The following is a description of a gene set: species: Homo sapiens Catalysis of the transfer of a galactose residue from a donor molecule to an oligosaccharide, forming a beta-1,3-linkage. Human Gene Set: GOMF_BETA_1_3_GALACTOSYLTRANSFERASE_ACTIVITY, and this is the list of marker genes: B3GNT5, C1GALT1C1L, B3GALT5 (beta-1,3-galactosyltransferase 5), B3GNT6, B3GALNT1, B3GALT1, B3GNT8, C1GALT1, B3GALT2, B3GNT2, C1GALT1C1, B3GNT3, B3GALT4, B3GNT7, B3GNT4